The following is a description of a gene set: An intracellular signaling cassette in which a small monomeric GTPase relays a signal. species: Mus musculus Mouse Gene Set: GOBP_SMALL_GTPASE_MEDIATED_SIGNAL_TRANSDUCTION, and this is the list of marker genes: Rnd1, Lat, Tgm2 (NCBI Gene Id 21817), Arhgap18, Dock3, Sgsm3, Fnta, Adgrg1, F11r, Lrp4, Srgap1, Rapgef6, Rapgefl1, Abl1, Nf1 (NCBI Gene Id 320618), Itsn1, Ralgapa2, Kif14, Plekhg5, Rab39b, Kndc1, Rtn4, Arfgap1, Gm14137, Camk2d, Map2k1, Dok1, Cdk2 (cyclin dependent kinase 2), Hacd3, Rhoc, Mapkap1, Ccdc88a, Ksr1, Eps8l2, Sos2 (NCBI Gene Id 20663), Rab12, Mapre2, Dok7, Gm266 (NCBI Gene Id 212539), Myo9b, Crk, Gabarap, Map4k4, Git2, Gmip, Musk, Arhgap24, Grin2b, Ywhaq, Baiap2, Tnfaip1, Mapkapk5, Rab3gap1, Arhgap42, Ccdc125, Hmox1, Arhgef28, Fbp1, Chn1, Usp50, Cyrib, Csf1, Heg1, Kbtbd7, Dgki, Rab39, Rap1gap2, Spry1, Prag1, Brap, Nucb1, Icmt, Tgfb2, Gdi1, Stard13, Tiam2, Rap1a, Flot1, Rasgrp1, Arhgap8, Sh2b2, Arhgap19, Tnk1, Ccdc88c, Micall2, Ssx2ip, Stmn3, Rap2b, Sh2d3c (SH2 domain containing 3C), Syde2, Ntn1, Gdi2, Cdc42ep3, Rnd2, Dhcr24, Lipa, Dnaja3, Rasgrp4, Psd, Arhgap20, Rock2, Arfgef2, Ripor2, Apoa1, Gpr4, Garnl3, Col1a2, Uso1, Eras, Grin2a, Arhgap25, Arhgdig, Cyth2, Fbxo8, Ephb2, Sos1, Abca1, Trp53, Rab30, Arfgef3, Rhob, Reln, Apoe, Rala, Adra1a, Cnksr1, Erbb3, Rab35, Crkl, Myoc, Nras, Arhgdib, Agtr1a, G3bp2, Dok2, Arhgap35, 4930544G11Rik, F2rl1, Rabl3, Ngf, Tax1bp3, Shoc2, Cul3, Was, Spry2, Akap13, Rhobtb2, Hras, Trim67, Iqsec1, Notch1, Grb2, Sipa1l2, Elmo1, Farp2, Cdc42se1, Dynlt1b, Slit2, Rhebl1, Rap2a, Rhoh, Dennd4a, Rhoq (NCBI Gene Id 80836), Picalm, Rasa4, Arhgap44, Gbf1, Rasgrp3, Arhgap22, Rasgef1c, Sdcbp, Cdc42, Rab9, Nfix, Mfn2, Rasa2, Rgl1, Dock9, Dock10 (dedicator of cytokinesis 10), Src, Bnip2, Rdx, Dock8, Cdc42se2, Cyth1, Dock7, Dynlt1f, Itgav, Nup62, Dock6, Stk19, Farp1, Arhgap30, Rab33b, Rasgef1a, Rabgef1, Dock11, Ccna2, Apoc3, Gna13, Ralgapa1, Arhgap29, Itgb1, Fxr1 (NCBI Gene Id 99741), Dock2, Ppp2cb, Rasa3, Arhgap17, Dennd4c, Kbtbd6, Arf6, Rasip1, Cdc42ep2, Tagap, Kctd10, Flcn, Stard8, Amot, Cdon, Ednra, Rab33a, Ralbp1, Dbnl, Kank2, Foxm1, Brk1, Cadm4, Plcd4, Rheb, Racgap1, Arhgef7, Iqsec2, Dgkz, Kctd13, Sh3bp1, Bcr, Ripor1, Tsc2, Git1, Rab9b, Ophn1, Arhgap12, Nradd, Dennd3, Vav2, Als2, Dnm2, Csnk1a1, Dynlt1a, Usp8, Rasgrf1, Madd, Lrrk2, Vav1, Kitl, Arhgap9, Rhobtb1, Igf1, Sema4d, Cyth4, Chm, Arhgef2 (Rho/Rac guanine nucleotide exchange factor 2), Rufy1, Chml, Shtn1, Rac3 (Rac family small GTPase 3), Cdkn1a, Rabif, Ralgps2, Rasgrp2, Cdc42ep5, Cavin4, Col3a1, Arhgef3, Garre1, Synj2bp, Rab4a, Psd4, Plaat1, Arhgap31, Arfgef1, Rassf1, Adra1b, Met, Iqsec3, Eps8, Rasgef1b, Ralb, Abi2, Iqgap3, Stmn1 (NCBI Gene Id 16765), Ctnnal1, Eps8l1, Fgf10, Itpkb, Rapgef1, Arhgef11, Rock1, Psd3, Plce1, Rtkn, Arhgap15 (Rho GTPase activating protein 15), Rnd3, Syde1, Rras2, Auts2, Arhgap32, Arhgef9, Vav3, Cdc42ep1, Arhgap40, Cgnl1, Cd2ap, Bcl6, Pdgfrb, Arhgap33, Pik3cb, Cyth3, Cdh2, Scai, Synpo2l, Rap1gap, Cbl, Itga3, Rsu1, Ntrk1, Rab4b, Rap1b, Pth, Notch2, Plxnb1, Eps8l3, Syngap1, Arrb1, Pik3cg, Rit1, Cdc42bpa, Epo, Rhof, Arhgap5, Nrg1, Celsr1, Arhgef18, Nucb2 (nucleobindin 2), Agtr1b, Spry4, Dab1, Mcf2l, Dynlt1c, Aif1, Rit2, Phactr4, Sipa1l1, Kank1, Ralgps1, Dock1, Rasal3, Wasf2, Cyfip1, Pdpn, Dennd4b, Nkiras1, Timp2, Rb1, Rapgef2, Ogt (NCBI Gene Id 77137), Adcyap1r1, Dlc1, Dock5, Rtn4r, Gpr55, Ulk1, Erbb2, Ralgapb, Rapgef4, Nckap1, Tiam1, Fermt2, Mmd2, Cdh13, Rasal1, Rhoa, Wnk1, Lpar2, Ralgds, Rapgef3, Kras, Robo1, Dock4, Arhgap28, Ksr2, Plk2, Vangl2 (NCBI Gene Id 93840), Nisch, Bcar3, Rac1, Rhoj, Psd2, Rgl2, Frmd7, Lztr1, Dab2ip, Arhgap27, Wasf1 (WASP family, member 1), Rhog, Arhgdia, Lpar1, Rac2, Net1, Rab21, Tns3, Arhgap1, F2r, Arhgap45, Sipa1, Rap2c, Agrn, Abra, Arl6, Stambp, Nrp1, Sipa1l3, Klk1b4, Mras, Nkiras2, Pecam1, Rhov, Rapgef5, Rgl3, Arhgef12, Dennd1a, Adrb1, Dok3, Rab15, Rhod, Arl3 (NCBI Gene Id 56350), Rasgrf2, Rfxank, Gna12, Ngfr (NCBI Gene Id 18053), Abl2, Cdc42ep4, Rhou